Given this list of marker genes Plcd1, Erlin1, Erlin2, Dgkq, Lpcat3, Nfkb1, Bmp6, P2ry1, Mbtps2, Scp2, Gpr146, Scap, Pex2, Bmp5, Clcn2, Cyp27b1, Prkg1, Apoe (NCBI Gene Id 11816), Gnai1, Pth, Avpr1b, Pth1r, Srebf2, Prkaca, Myh9, Dhcr7, P2ry6, Lhcgr, Gper1, Mas1, Srebf1, Adcyap1r1, Gfi1, Qki, Insig1, Isyna1, Mapk1 (mitogen-activated protein kinase 1, NCBI Gene Id 98012), Wnt4, Npy1r, Fdps, Plek, Rest, Apob, Idi2, Bmp2, Ptafr, Cyp7a1, Dab2, Sod1, Paqr3, Abcg4, Pou1f1, Aqp8, H6pd, 3110082I17Rik, Cd244a, Sec14l2, Abcg1, Dkk3, Snca, Por (cytochrome p450 oxidoreductase), Ntsr1, Fgf1, here is a description of the gene set: Any process that modulates the frequency, rate or extent of alcohol biosynthetic process. Mouse Gene Set: GOBP_REGULATION_OF_ALCOHOL_BIOSYNTHETIC_PROCESS species: Mus musculus